Given this list of marker genes TGFB1, MIF, TRIM6, SYK, CALHM6, HTR2A, FFAR3, BST2, SLC7A5 (NCBI Gene Id 8140), LACC1, CD36, TRAF2, ANGPT1, CD81, IRF5, HLA-G, UBE2J1, TLR3, KIT, MAP3K7, GPRC5B, NLRP3, TGFB2, NLRX1, CD7, SIRT1, B2M, IL1R1 (interleukin 1 receptor type 1), TRPM4, BCL10, DDX21, CD226, SCIMP, RIPK2, SLAMF1, TICAM1, AXL, BTK, ACP5, LITAF, TNFRSF14, SECTM1, JAK3 (NCBI Gene Id 3718), CD55, PRG2, RAET1G, CCR2, SPHK2, MYD88, PKP3, IFNA2, ARID5A, CARD9, TGFB3, MAVS, TBX21, APOA2, TNFSF4, TNF, CUEDC2, HLA-E, TRAF6, BCL6, WNT5A, DHX36, DDX1, IL18R1, LILRB4, IL6, TLR7, SASH3, NR4A3, FCER1G (Fc epsilon receptor Ig), HLA-F, PANX1, P2RX7, MIR302A, TLR4, EPX, RSAD2, DEFB131A, CD96 (NCBI Gene Id 337949), INAVA, DENND1B (DENN domain containing 1B), FFAR2, IL1B, CD74, SEMA7A, ATG5, ARG1, CAMK4, NOD2 (NCBI Gene Id 8135), TWIST1, IL18, HLA-A, HK1, CLC, KIR2DL4 (killer cell immunoglobulin like receptor, two Ig domains and long cytoplasmic tail 4), CLEC7A, FOXP3, MALT1, TRIL, LAPTM5, TNFRSF1B, F2RL1, SPON2, ATG9A, LILRB1, XCL1, IL10, CD160, NOD1, IL21, PLCG2, IFNB1, PYCARD, IL4, IRAK3, HFE, RTN4, GATA3, APOA1, FZD5, MAPKAPK2, CLNK, PRKCZ, TLR9, RABGEF1, RIGI, SMAD7, here is a description of the gene set: Human Gene Set: GOBP_CYTOKINE_PRODUCTION_INVOLVED_IN_IMMUNE_RESPONSE species: Homo sapiens The appearance of a cytokine due to biosynthesis or secretion following a cellular stimulus contributing to an immune response, resulting in an increase in its intracellular or extracellular levels.